The following is a description of a gene set: Mouse Gene Set: REACTOME_FANCONI_ANEMIA_PATHWAY species: Mus musculus Fanconi Anemia Pathway, and this is the list of marker genes: Faap100, Slx4, Fance, Wdr48, Uba52rt, Fancm, Ercc4, Faap20, Dclre1b, Fancg, Ubb, Fancf, Mus81, Slx1b, Fanci, Cenpx, Rpa2 (replication protein A2), Faap24, Rpa1, Cenps, Fancl, Rpa3, Eme2, Ubc, Eme1, Dclre1a, Rps27a, Atrip, Fanca, Ube2t, Fancb, Ercc1, Poln, Fancc, Uba52, Fan1, Fancd2, Usp1